Given this list of marker genes RMI1, ATR, MSH6, RFC3, RHNO1, NTHL1, RMI2, NBN, MSH2 (NCBI Gene Id 8169), RAD51B, BLM, RAD51, MUTYH, OGG1, BRCA2, RPA2, SEM1, RAD51AP1, RAD51C, NEIL1, XRCC2, MLH1, ATRIP, RFC2, RFC4, MRE11, MSH3, BARD1, PALB2, RPA1, KAT5, DNA2, TOPBP1, RAD9B, RAD1, HUS1, RAD17, BRCA1, RPA3, NEIL3, RAD51D, BRIP1, TOP3A, RBBP8, PMS2, ATM, RFC5, WRN, RAD50, EXO1 (NCBI Gene Id 9156), RAD9A, here is a description of the gene set: studied in species Homo sapiens part of: Disease Reactome Pathway: Diseases of DNA repair Germline and somatic defects in genes that encode proteins that participate in DNA repair give rise to genetic instability that can lead to malignant transformation or trigger cellular senescence or apoptosis. Germline defects in DNA repair genes are an underlying cause of familial cancer syndromes and premature ageing syndromes. Somatic defects in DNA repair genes are frequently found in tumors. For review, please refer to Tiwari and Wilson 2019.<br><br>We have so far annotated diseases of mismatch repair, diseases of base excision repair and diseases of DNA double-strand break repair.<br><br>Defects in mammalian DNA mismatch repair (MMR) genes (MLH1, PMS2, MSH2, and MSH6) result in microsatellite instability (MSI) and reduced fidelity during replication and repair steps. Defective variants of MMR genes are associated with sporadic cancers with hypermutation phenotypes as well as hereditary cancer syndromes such as Lynch syndrome (hereditary non-polyposis colorectal cancer) and constitutional mismatch repair deficiency syndrome (CMMRD). MSI is an important predictor of sensitivity to cancer immunotherapy as the high mutational burden renders MSI tumors immunogenic and sensitive to programmed cell death-1 (PD-1) immune checkpoint inhibitors. For review, please refer to Pena-Diaz and Rasmussen 2016, Sijmons and Hofstra 2016, Tabori et al. 2017, Baretti and Le 2018.<br><br>Germline mutations, single nucleotide polymorphisms (SNPs) and somatic mutations in several genes involved in base excision repair (BER), a DNA repair pathway where a damaged DNA base is excised and replaced with a correct base, are involved in the development of cancer and several oxidative stress-related diseases. For review, please refer to Fu et al. 2012, Fletcher and Houlston 2010, Brenerman et al. 2014, Patrono et al. 2014, and D'Errico et al. 2017.<br><br>Germline mutations in genes involved in repair of DNA double-strand breaks (DSBs) are the underlying cause of several cancer predisposition syndromes, some of which also encompass developmental disorders associated with immune dysfunction, radiosensitivity and neurodegeneration. Somatic mutations in genes involved in DSB repair also occur in sporadic cancers. For review, please refer to McKinnon and Caldecott 2007, Keijzers et al. 2017, and Jachimowicz et al. 2019.